The following is a description of a gene set: studied in species Homo sapiens Genes up-regulated in peripheral blood mononuclear cell non-responders vs responders in adults (<50) after exposure to Heptatitis B surface antigen vaccine (HBsAg), time point 7D Human Gene Set: QIU_PBMC_HEPTATITIS_B_SURFACE_ANTIGEN_AGE_UNDER50_NON_RESPONDERS_VS_RESPONDERS_7DY_UP from publication Qiu S, He P, Fang X, Tong H, Lv J, Liu J, Zhang L, Zhai X, Wang L, Hu Z, Yu Y (PMID 29580160) Individuals fail to elicit protective antibody after hepatitis B vaccination remain at risk for hepatitis B virus infection. Analysis of the transcriptome of peripheral blood mononuclear cells (PBMCs) is essential to elucidate the characteristics of gene expression in non-responders. In this study, we enrolled seven responders who had received three injections and seven non-responders who had six injections of hepatitis B vaccine before. All the participants were then vaccinated with a three-dose boost regimen. Microarray analysis and Luminex assay were applied to examine mRNA expression and Th1/Th2/Th9/Th17/Th22/Treg cytokine and chemokine profiles in non-responders and responders. Differentially expressed genes in PBMCs of non-responders at 5 time points, i.e. pre-vaccination, 3<sup>rd</sup>, 7<sup>th</sup>, 28<sup>th</sup> day post the first dose vaccination and 7<sup>th</sup> day post the second dose vaccination indicated a dense network trend. Compared with responders, nine coding genes (BPI, DEFA1B, DEFA4, CEACAM8, MMP8, FOLR3, LTF, TCN1 and TKTL1) were significantly up-regulated in non-responders at all 5 time points, which could probably be the characteristic genes in hepatitis B vaccine non-responsiveness. Gene ontology analysis revealed that most of the DEGs were related with immune responses. Validation results of these genes using quantitative real-time polymerase chain reaction were mostly consistent with the results of microarray. Cytokine analysis demonstrated that IL-27 and CXCL12 concentrations in responders were significantly higher than non-responders on the 3<sup>rd</sup> day after the first dose and 7<sup>th</sup> day after the second dose of vaccination, respectively. No significant difference was observed in other cytokine and chemokine signatures between the two groups. In conclusion, our results revealed characteristic transcriptome and cytokine changes in hepatitis B vaccine non-responders after boost immunization., and this is the list of marker genes: SERPINB2, KCNJ2, IL23A, F3, IFNG, IL1RN, KMO, ANXA3, ARG1 (arginase 1), CRISP3, MS4A3, RIN2, MIR3945HG, LACC1, DEFA1B, TKTL1, LTF, IRAK2, CEACAM8 (CEA cell adhesion molecule 8), KCNJ2-AS1, DEFA4, MMP8 (NCBI Gene Id 4317), ZC3H12C, TCN1, FOLR3, TNF, CXCL8, KISS1R, DLX4, TNFAIP6, CCL4, RNASE3